Given this list of marker genes Pim1, Stat1, Mier3, Ifi47, Iigp1, Irf8, Akna, Gbp7, Irgm2, Txndc15, Irf1, Lratd2, Fzd6, Dennd4b, Igtp, Tap1, Rnf220, Tmem183a (NCBI Gene Id 75635), Socs1, Smcr8 (NCBI Gene Id 69685), Gbp2, Pdhx, Gbp5, here is a description of the gene set: Genes positively differentially expressed in cell type: Mast cell upon treatment with cytokine: IL-18 in mouse lymph nodes in vivo. studied in species Mus musculus from publication Cui A, Huang T, Li S, Ma A, Pérez JL, Sander C, Keskin DB, Wu CJ, Fraenkel E, Hacohen N (PMID 38057668) Mouse Gene Set: CUI_MAST_CELL_IL18_RESPONSE_UP Cytokines mediate cell-cell communication in the immune system and represent important therapeutic targets. A myriad of studies have highlighted their central role in immune function, yet we lack a global view of the cellular responses of each immune cell type to each cytokine. To address this gap, the authors created the Immune Dictionary, a compendium of single-cell transcriptomic profiles of more than 17 immune cell types in response to each of 86 cytokines (>1,400 cytokine-cell type combinations) in mouse lymph nodes in vivo. A cytokine-centric view of the dictionary revealed that most cytokines induce highly cell-type-specific responses. For example, the inflammatory cytokine interleukin-1β induces distinct gene programmes in almost every cell type. A cell-type-centric view of the dictionary identified more than 66 cytokine-driven cellular polarization states across immune cell types, including previously uncharacterized states such as an interleukin-18-induced polyfunctional natural killer cell state.